The following is a description of a gene set: studied in species Mus musculus Mouse Gene Set: GOBP_HOMEOSTASIS_OF_NUMBER_OF_CELLS Any biological process involved in the maintenance of the steady-state number of cells within a population of cells., and this is the list of marker genes: Gpr174, Brinp1, Kif3a, Cyld, Isg15, Cxcr2, Mir451b, Septin4, Spns2, Tuba1a, Mertk, Epb42, Dnase2a, Rac2, Dmtn, Nod2, Exoc5, Plcb1, Racgap1, Chmp5, Skil, Fech, Fas, Pacs1, Hbb-bs, Nos3, Col6a1, Fosl2, Glis2, Sp3, Arhgef5, Il20rb, Hmgb1, Prkdc, Crispld1, Rps19, Lmo2, Bax, Tgfbr3, Dock11, Gata3, Mecom, Slc46a2, Ada, Dyrk3, Hmox1, Slc39a3, Fcgr2b, Gm15915, Tet2, Bbs4, Hoxa5, Klf2, Ankle1, Card11, Rps14, Adgrg1, Hnrnpu, Lgr4, Il2ra, Slc4a1, L3mbtl3, Smad5, Bmi1, Epsti1, Fh1, Heph, Ank1, Dock10, Epg5, Nbea, Bpgm, Il7, Uba5, Slc7a11, Mtch2, Pik3cd, Alas2, Slc37a4, Tnfsf4, Csf1, Bap1, Sox9, Rb1, Cd24a, Kitl, Znhit1, Sh2b2, Chst3, Col14a1, Nppb, Adgrf4, Prmt1, Cdin1, Ncapg2, Arsg, Cxcl5, Pkn1, Aim2, Hmga1, Gpam, Ercc2, Hba-a1, Poc1b, Ezh1, Ubap2l, Sox4, Kmt2a, Cdk6, Vps54, Hmgb2, Carmil2, Zfp36, Bak1, Ccn3, Tal1, Fam210b, Exoc6, Cd7, Acvr2a, Muc2, Zfp251, Tnfrsf17, Zfx, Nle1, Notch1, Cebpg, Gimap5, Vhl, Minar2, Cited2, Pth, Ppp2r1a, Tex15, Id2, F2r, P2ry14, Med1, Rag1, Smarca4, Axl, Trgc1, Zbtb18, Stat5b, Odad3, Vegfa, Ptbp3, Tsc22d3, Cd74, Itgam (NCBI Gene Id 16409), Dnaja3, Mpig6b, Prdm14, Smarca2, Tmod3, Itpkb, Wdr48, Ets1, Ppp2ca, Abl1, Flt3, Gpr183, Casp3, Traf3ip2, Ap3b1, Rpa1, Il7r, Inpp5d, Hspa1b, Il18, Ampd3 (NCBI Gene Id 11717), Lmo1, Hscb, Tspan9, St6galnac1, Adgrf5, Gnat2, Kcnq1, Sod1, Stat5a, Lyar, Atp5if1, Pianp, Stat3, Ezh2, Hspa9, Sos1, Pde4b, Fance, Slc40a1, Lpcat3, Prdx5, Pik3cb, Card9, Mafb, Alas1 (NCBI Gene Id 57445), Gcnt4, Tmem14c, Epas1, Rrn3, Hcls1, Afdn, Ccr7, Fsip1, Myct1, Gpr15lg, Mfhas1, Bloodlinc, Lrrc19, Coro1a, Ccl2 (C-C motif chemokine ligand 2), Men1, Rc3h2, Gfi1b, Tcirg1, Jak3, Zfpm1, Mapk14, Siva1, Glul, Nlrp6, Gpi1, Ahr, Sh2b3, Sco1, Ncstn, Cd44, Fancc, Inhba, Ripk3, Tnfrsf4, Rps6, Tcf3, Add1, Sprr2a1, Bloc1s6, Gimap3, Polb, Mir150 (NCBI Gene Id 387168, microRNA 150), Gigyf2, Bmp4, Trim58, Smo, Ehbp1l1, Prdx1, Hba-a2, Diaph3, Nfix, Sp1 (NCBI Gene Id 68485), Gba1, Flt3l, Akt1, Thra, Ildr2, Epo, Tspo2, Btk, Sfxn1, Srf, Tcea1, Xiap, Jmjd6, Stat1 (signal transducer and activator of transcription 1), Heatr3, Hcar2 (NCBI Gene Id 80885), Mir142hg, Foxp3, Sit1 (suppression inducing transmembrane adaptor 1), Klhl10, Gata1, Tnfsf13b, Gprasp2, Bcl6, Slc25a5, P4htm, Myb, Arid4a, Vpreb1b, Ext1, Foxa3, Pantr2, Rac3, Ikzf1, B2m, Adam17, Gapt, Muc19, Ahsp, Mb, Il3, Armcx1, Scnn1b, Hdac6, Bcr, Xkr8, Maea, Sart3, Cdk5rap3, Pla2g10, Emcn, Tnfrsf13c, Rac1, Brd1, Kmt2e, Rcor1, Wdr37, Ufl1, Rps17, Axin1, Cd47, Caml, Adar, Foxn1, Slc48a1, Rc3h1, Zc3h8, Rbfox2, Sox6, Bcl2, Prdx2, Cdh2, Ncor1, Cfh, Nkx2-3, Map7, Trim10, Bcl10, Ccnb2, Ift88, Elp6, Rhag, Klf13, Cfap70, Hif1a, Mthfd1, Slc15a4, Enpp1, Sash3, Hba-x, Rhd, Ptpn11, Slc25a38, Kdm1a, Foxo3, Gm36723, Hc, Setd1a, Jak2, Slc1a5, Pirb, Cadps2, Senp1, G6pdx, Jam3, Lyn, Kit, Ireb2, Pknox1, Asxl1, Ifng, Lat, Gata2, Stat4, Afp, Vpreb1a, Ccr4, Nemp1, Slc11a2, Kras, Bcl2l11, Spi1, Lilrb4a, Flvcr1, Ypel4, Mir122, Ikbkb, Mir451a, Mir144, Vps13a, Tnfrsf13b, Emx1, Bcl2a1a, Tnfaip3, Tgfb1, Hoxb6, Mef2c, Nf1, Csf1r, Acin1, Ptpn2, Abcb10 (NCBI Gene Id 97438), Mpl, Pmaip1, Fadd, Lgals2, P2rx7, Ppp2r3c, Mir125a, Selenow, Bbip1, Cx3cr1, Nfe2l1, Fam3d, Sos2, Etv2, Fbxo21, Slc25a40, Ldb1, Fcer1g, Nckap1l, Akt3, G6pd2, Lipa, Spta1, Fstl1, Nfkbiz, Mif, Pla2g2a, Hamp, Ikbkg, Smap1, Ankrd54 (NCBI Gene Id 27619), Il6, Il2, Rps24, Zfp36l1, Zbtb7a, Ccr2, Acvr1b, Ppp3cb, Anxa1, Atxn2 (NCBI Gene Id 320857), Rassf2, Tgfb2, Napepld, Klf1, Kat7